The following is a description of a gene set: studied in species Homo sapiens Human Gene Set: GOBP_RESPONSE_TO_NUTRIENT_LEVELS Any process that results in a change in state or activity of a cell or an organism (in terms of movement, secretion, enzyme production, gene expression, etc.) as a result of a stimulus reflecting the presence, absence, or concentration of nutrients., and this is the list of marker genes: TMEM135, PDX1, PTER, WDR59, MED1, GAST, CYP26A1, SCAP, ACVR1C, PRLH, CYBB (cytochrome b-245 beta chain), PICK1, METTL14, PAK4, PRKAB1, ALAD, MAP1LC3B, FOXO3, RARA, SEC13, GRIA1, SST, CLPSL1, IGFBP2, NCOA3, ATG7, SPP1, SRD5A1, ASNS, NCOA1, ENSA, NMUR2, PAK2, PLEC, GPR82, NFKBIZ, INHBA, PRKAG1, MYOD1, RASAL2 (RAS protein activator like 2), JMY, PAK3, LARS1, PPARG (NCBI Gene Id 5468), GUCA2B, NPFF, SREBF2, TRIM24, VDR, SRD5A2, CDKN2B, IL15RA, HSPA8, PLD1, ADRB1, MCU, CREBBP, TFAM, FOLR1, TSC1, UCN2, SCTR, LEP, SAMTOR, EIF4G1, MTOR, GDF3, BCAS3, HNRNPA1, GHRH, WNT4, CDKN1A, POMC, MAT2A, TRIM32, YME1L1, ATF4, CAV1, TPCN2, MLYCD, SLC34A1, STK26, CSH2, MAP1B, ARSB, CD4, SEH1L, TBL2, SNAI2, CADPS2, WNT9B, FASN, SESN3, PRKAA1, CBL, LAMTOR1, PTH, MKKS, TYR, MYBBP1A, OXT, HFE, VGF, SESN1, RELA, LTA, BAX, CSNK1A1, GHSR, EIF2AK2, SLC38A3, BNIP2, NPY, FGF23 (NCBI Gene Id 8074), NPPC, FUT1, BECN2, GCGR, HTR2C, CARTPT, ABCC8 (ATP binding cassette subfamily C member 8), PAGE4, SESN2, MAPK1, RIPOR1, SLC16A1, CLPSL2, F7, PRKAA2, KRT20 (keratin 20), PRKCH (protein kinase C eta), TSC2, GABARAPL2, HIGD1A, TFRC, GBA1, ITFG2 (integrin alpha FG-GAP repeat containing 2), ASL, TGFB1, PCK2, ADSS1, PIK3C3, RNF152, SLC22A3, GABARAPL3, GABARAPL1, WNT2B, TNC, PRKD1, TMIGD1, DRAM1, SMDT1, MLXIPL, C2, LARP1, TRIM25, APOE, KCNB1, BGLAP, UCP3, FADS1, GPR155, SAR1A, POSTN, TBL1XR1, DSC2, G6PD (NCBI Gene Id 83159), CPEB4 (NCBI Gene Id 80315), GH2, RXRB, AKT1, GCLM, CLEC16A (NCBI Gene Id 441746), BCKDHB, CSH1, ALB, ITGA2, HTR4, KAT2B, RNF167, MBD3, PHEX (NCBI Gene Id 5251), YWHAG, AMELX, WRN (WRN RecQ like helicase), PPARD, PRL, DDIT3, PRR5, GHR, NENF, TRPV4, PRKAG2, PRMT1, GIPR, CD40, MT3, CSHL1, USF1, PTPN1, CYP26B1 (cytochrome P450 family 26 subfamily B member 1), RMI1, ACACB, LRP11, SLC2A1, MPO, GH1, KYNU, PIM1, OTC, TRPA1, LIPA, UCN3, TP53, EP300, ATG5, PAK6, ULK3, RRAGD, SORL1, FAM107A, OMA1, SOX2, EIF2A, BBS2, SFRP1, SOD2 (NCBI Gene Id 79099), USP33, EEF2, BMP7, YWHAZ, OXCT1, FLCN, STAT1, TMEM126B, MAPK8, HRK, GLUL (NCBI Gene Id 2752), MEAK7, CLPS, KAT2A, GPRIN3, SLC25A25, ACAT1, RRP8, RXRA, XBP1, WNT11, F5, ATXN3, ADRB2, H6PD, GNAI2, YARS1 (tyrosyl-tRNA synthetase 1), PLIN3, ABCG8, LDLR, MDM2, RRAGC, MAP1LC3A, EIF2S1, ELAPOR1, CAD, IFI16, FBXO22, STC2, RALB, HSD11B2 (hydroxysteroid 11-beta dehydrogenase 2), MYH13, TBC1D7, CYP24A1, PRKAG3, PROX1, MT-CYB, PCK1, GDF15, PDK2, MAP3K5, SFRP2 (NCBI Gene Id 6423), GCN1, GAS6, PPARA, BCHE, MICU1 (NCBI Gene Id 51415), NUPR2, LRAT, BCL2, PDK4, PPARGC1A (PPARG coactivator 1 alpha), NTRK1, SP1 (Sp1 transcription factor), USF2, DNMT3A, STK39, DELE1, KAT5, MIR125B1, LCN2, STC1, SP7, SH3GLB1, UCP1, POR, CEBPA, EHMT2, CXCL10, ATG14, BBS4, G6PC1, NOD2, PSPH (NCBI Gene Id 5723), SLC38A2, MAP1LC3B2, FAS, PLIN2, PAK1, SLC27A4, NR1H4, LPL, CPT1A, FNIP1, CYBA, SCT, C1QTNF4, CD68, CHSY1, MIOS, OTUD3, FOXA3, SLC6A19, ADRB3, VPS41, WDR45B (WD repeat domain 45B), COL6A1, TNFRSF11A, PRKCG, CCL28, PPM1D, ABCG5, KANK2, PEX2, AKR1C3, CDKN2D (cyclin dependent kinase inhibitor 2D), PIK3R4, IMPACT, MTHFR (NCBI Gene Id 4524), CASR, AGL, GATA4, GALP, TBC1D5, FOLR2, ZFYVE1, NUAK2, TTC5, CYP1A1, PKLR, ATN1, NNT, MAF, BHLHA15, ZFP36, BECN1, EIF2AK3, ETNPPL, RPS6KB1, UCP2, SPX, SAR1B, TSPO, CPS1, ASCL1, ALPL (alkaline phosphatase, biomineralization associated), PAK5, SREBF1, SLC39A4, HSF1, MTMR3, ULK2, LIPG, GHRL, COL1A1, WNK4, SNW1, BMP8A, APPL2, RPTOR, HLCS (NCBI Gene Id 3141), MLST8, FIS1, BNIP1, MAP1LC3C, ZC3H12A, PIK3C2B, ADSL, TNRC6A, TNF, COX4I1, MBD2, ASS1, CNTN2, PENK, KPTN, NPRL2, SIRT2, ACSL1, CHKA, GFRAL, MAPKAP1, HMGCS2, APAF1, ADIPOQ, DNAJC15, NPRL3, MC4R, WIPI1, CIDEB (cell death inducing DFFA like effector b), KLF10, SCNN1B, NR1H2, SIRT1, TBXA2R, UPP1, GPX1, BMPR2, MFSD2A, SLC39A5, EIF2AK1, RICTOR (RPTOR independent companion of MTOR complex 2), ABCA1, BNIP3, RHEB, MN1, RARRES2, PMAIP1, FES, ABCB1, RRAGA, SGIP1, CASTOR1, MAPK3, CYP27B1, ENSG00000274276, FOXK2, KICS2, CBS, STK24, ULK1, FBN1, GDAP1, CCND1 (NCBI Gene Id 893), HCRT, BCL10, VCAM1, KL, LAMP2, LGSN, INHBB, PCSK1N, DGAT2, XPR1, TRPV1, GIP, WDR45, SUV39H1, GSTP1, FOXO4, GAS2L1, SLC10A1, ALDH1A2, PCSK9, GCLC, COMT, FOXK1, OGT, ACADM, PRKAB2, UCN, SRF, AQP3, ATF2, ALAS1, FOS, ATF3, NFE2L2, LRRK2, SZT2, RRAGB, PARP2, AMBRA1, SLC7A5, EIF2AK4, EPO, TFEB, WIPI2, CYP8B1, SSTR1, HDAC3, CAT, FOXO1, KCNJ11, GABARAP, ZEB2, MAPK14, SIRT5, MAFB, HSPA5 (heat shock protein family A (Hsp70) member 5), GPR180, FBP1, SLC6A4, WDR24, SOD1, DEPDC5